The following is a description of a gene set: BACKGROUND: Dendritic cells (DC) play a central role in primary immune responses and become potent stimulators of the adaptive immune response after undergoing the critical process of maturation. Understanding the dynamics of DC maturation would provide key insights into this important process. Time course microarray experiments can provide unique insights into DC maturation dynamics. Replicate experiments are necessary to address the issues of experimental and biological variability. Statistical methods and averaging are often used to identify significant signals. Here a novel strategy for filtering of replicate time course microarray data, which identifies consistent signals between the replicates, is presented and applied to a DC time course microarray experiment. RESULTS: The temporal dynamics of DC maturation were studied by stimulating DC with poly(I:C) and following gene expression at 5 time points from 1 to 24 hours. The novel filtering strategy uses standard statistical and fold change techniques, along with the consistency of replicate temporal profiles, to identify those differentially expressed genes that were consistent in two biological replicate experiments. To address the issue of cluster reproducibility a consensus clustering method, which identifies clusters of genes whose expression varies consistently between replicates, was also developed and applied. Analysis of the resulting clusters revealed many known and novel characteristics of DC maturation, such as the up-regulation of specific immune response pathways. Intriguingly, more genes were down-regulated than up-regulated. Results identify a more comprehensive program of down-regulation, including many genes involved in protein synthesis, metabolism, and housekeeping needed for maintenance of cellular integrity and metabolism. CONCLUSIONS: The new filtering strategy emphasizes the importance of consistent and reproducible results when analyzing microarray data and utilizes consistency between replicate experiments as a criterion in both feature selection and clustering, without averaging or otherwise combining replicate data. Observation of a significant down-regulation program during DC maturation indicates that DC are preparing for cell death and provides a path to better understand the process. This new filtering strategy can be adapted for use in analyzing other large-scale time course data sets with replicates. Human Gene Set: GSE21033_CTRL_VS_POLYIC_STIM_DC_24H_UP species: Homo sapiens from publication Olex AL, Hiltbold EM, Leng X, Fetrow JS (PMID 20682054) Genes up-regulated in bone marrow-derived dendritic cellstreated by poly(IC): 0h versus 24h., and this is the list of marker genes: ADCY7, TNFRSF14, S1PR4, CLIP1, TECR, SPG11, MYO1G, SLC29A2, SEC24C, IER5L, SCAPER, TTYH2, PGAP1, CCR7, ENTPD6, RNF149, TELO2, ZFP36L1, TAGLN2, NCOA2, PIGV, CYTH3, EIPR1, XPOT, IKBKE, ABHD14A, GPR65, UNKL, SLC16A6, PACS1, NPC2, RIPOR2, SHISA5, IFNB1, LGMN, TNFAIP8L2, SELENOP, TANC1, RAPGEF4, LMBR1L, DTX1, DLX4, OCIAD2, CPM, CEP295NL, RUNDC3B, USP24, ABHD11, GGT1, BRI3BP, BNIP3, SELL, POLR1B, IVD, EYA2, BOLA2, FOXO1, EVL, DSE, LY9, TENT5C, PYHIN1, PITPNM1, BCKDHB, FGD3, PRKAA1 (protein kinase AMP-activated catalytic subunit alpha 1), BZW2, CARD6, CTSC, RNF13, GATA1, CHD2, UBASH3A, AKT3, SLC20A1, SSH2, DYRK2, GPR18, RPRD2, ITM2B, ARHGAP25, OSTF1, IPCEF1, UTRN, MAP3K3, PDE4B, GPRC5B, IGFN1, ATP8B4, TNFRSF1A, LDLRAP1, MAGEA9, TMEM154, CARD9, MIR142, HINT3, FXYD5, ELOVL6, GM2A, GLRB, IL18RAP, PITPNC1, CYLD, IL12RB2, H19, KCNMB1, S100A10, KLHL3, ACADSB, RASA3, HEXB, GIMAP3P, MAFG, THEM5, SFXN2, PRKCH, CDON, MSL1 (MSL complex subunit 1), PCCA, PVT1, FBXL20, ADAMTS10, MYO1F, TBX6, UBE2E2, GIMAP7, RPL13A, FBLL1, NRP1, TRIB2, TMEM185A, TRAP1, SLC50A1, PTPN22, CYTH4, SLFN5, NAV2, MOB3C, ISCA2, CD226, AFDN, JAK1, MFNG, SCML4, SMAP2, KCNA2, CPQ, TMEM108, SLC27A6 (NCBI Gene Id 28965), AGFG1, BAIAP3, LRRTM4, STARD5, ELOVL7, NXPH1